Given this list of marker genes H2AX, DNMT3A, HSF5, UBE2B, SUMO1, PBX4, DMRTC2, BIRC2, SPDYA, MAEL, ESCO2, BRCA1, SIN3B, SMARCC1, PLK4, SMARCB1, here is a description of the gene set: species: Homo sapiens A structure found in a male mammalian spermatocyte containing an unpaired X chromosome that has become densely heterochromatic, silenced and localized at the nuclear periphery. Human Gene Set: GOCC_XY_BODY